The following is a description of a gene set: from publication Hoffmann R, Lottaz C, Kühne T, Rolink A, Melchers F (PMID 17890238) Genes up-regulated during B lymphocyte differentiation: pre-B I versus VPREB1+ large pre-B II. studied in species Homo sapiens Cells from four develppmental stages were purified by FACS from human bone marrow samples Human Gene Set: GSE4590_PRE_BCELL_VS_VPREB_POS_LARGE_PRE_BCELL_UP, and this is the list of marker genes: BRWD3, JAKMIP3, WHAMM, TBC1D22B, PPP2R2A, IL18BP, FAM81A, L3MBTL1, INSRR, MAGED1, TTC39B, RASIP1 (NCBI Gene Id 54922), ALDH1L1, COL11A1, PLAGL1, TBC1D13, DMRTC2, OASL (2'-5'-oligoadenylate synthetase like), RECK, IL23R, RSBN1L, RPS6KA6, ZCCHC2, MESP1, HTR2A, FRZB, TBATA, PCBP4, ARL5C, SMURF1, FMNL2, NOD1, IRGM, CRLF3, PRSS3P1, PML, UACA, IL12RB1, PLA2G1B, CTLA4, MFSD9, ETNK2, UPP2, RASGRP1, LHX2, ROS1 (ROS proto-oncogene 1, receptor tyrosine kinase), HEG1, GYPC, GKAP1, ZDHHC2, TBC1D12, ARHGEF12, RMDN3, STARD8, KLF8, ARL4A, NAA20, SLC37A3, NFKBID, MAGED2, LY75, RAB38, CD96, BTN2A2, PRKCQ, POU6F1, KLRK1 (killer cell lectin like receptor K1), STAU2, MFAP5, WARS1, NLRC5, PRKX, TSPAN1, PHYH, ARHGAP6, WFDC5, PIGZ, TMEM9, PCDHB3, ANKRD17, CSN1S1, IL18RAP (NCBI Gene Id 8807), ANGPT1, THSD7A, NETO2, PELI1, TBX15, CYSLTR2, PNMA1, GYG1, TAF9B, NOS1, CMPK2 (NCBI Gene Id 129607), ABHD16A, COX17, CDS1, MXD1, NUDT12, NEFM, DHX58, RCBTB1, SHOC1, MED12L, PCBP3 (poly(rC) binding protein 3), PTTG1, CRIM1, SEC24B, CLDN15, MAGOHB, PTCH1, IKZF1, HEBP1, TNKS1BP1, LYG1, TCF23, HAP1, RABGAP1L, NALCN, TTC3, DCBLD2, PDGFD, VPS37B, FRMD4B, MSL3B, TPBG, HAND1, MINPP1, PCGF2, SVBP, COBLL1, AK3, CALB2, C11orf68, PKD2L1, CHRNA5, PIK3R6, PNMA3, ACOT9, PIGP, NPDC1, PFN2, LPAR1, GNB4, CNDP2, MAPK11, ME3, TEKT5, CASP8, CDYL2, C2CD4A, CD2AP (CD2 associated protein), HMGN1, LYSMD2, IRF5, PAX5, CD38, SOCS7